The following is a description of a gene set: studied in species Homo sapiens Abnormally low-pitched voice A persistent (minutes to hours) abnormal decrease in the pitch of the voice for the context or social situation or significantly different from the baseline of the individual. Human Gene Set: HP_ABNORMALLY_LOW_PITCHED_VOICE, and this is the list of marker genes: RAD21, TRPS1, SMC1A, CFL2, GRIN2A, NSD1, SRPX2, HDAC8, TAF6, BRD4, SMC3, EZH2, NIPBL, SUZ12